The following is a description of a gene set: Human Gene Set: GOMF_2_IRON_2_SULFUR_CLUSTER_BINDING species: Homo sapiens Binding to a 2 iron, 2 sulfur (2Fe-2S) cluster; this cluster consists of two iron atoms, with two inorganic sulfur atoms found between the irons and acting as bridging ligands., and this is the list of marker genes: NDUFS1, FECH, CIAPIN1, ISCU, CISD1, NDUFV2, CISD2, AIFM3, SLC25A39, BOLA2B, NFU1, ISCA1, UQCRFS1, AOX1, ISCA2, FBXL5 (F-box and leucine rich repeat protein 5), SDHB, FXN, UQCRFS1P1, BOLA2, XDH, RFESD, FDX2, KIAA0753, CISD3, GLRX2, FDX1, GLRX5